The following is a description of a gene set: from publication Chen Y, Wang X (PMID 31504780) Genes predicted to be targets of miRBase v22 microRNA hsa-miR-4731-3p in miRDB v6.0 with MirTarget v4 prediction scores > 80 (high confidence targets). Human Gene Set: MIR4731_3P species: Homo sapiens, and this is the list of marker genes: EPHA5, NUP54, CNOT1, CNOT7 (NCBI Gene Id 29883), SNRPB2, TP53TG3B, GAD2, PCDHA4, ELL2, UBE3A, NECTIN1, SGIP1, DDX3X, HIPK1, RBM27, CYRIA, IRF5, RAB9B, RYBP, SLC16A1, FAM193A, GLRA2, ABHD13, KIF26B, LDHA, LUC7L3, PCDHA5, SCG2, RNF220, ZNF382, ZNF605, UCK2, DOCK3, PCDH9, AUTS2, CCDC71L, CCL23, ASIC2, TP53TG3D, HSPD1, ZNF706, LRP12, RTN4R, JAG2, SCGB2A1, FAM117A, CRKL, NAT1, UBE2B, SLC26A5, PTPN9, PARPBP, RRAS2, TRIO, NAP1L3, CCDC184, ZFPM2, SAMSN1, PCDHA12, RFX3, SRP68, NUDT16, TMEM35A, FBXL5, UBR3, IMMT, ITGB5, DHX38, RB1, TLX1, PITPNB, HACD3, NRP1, BMPR2, PCDHAC1, GTPBP3, TP53INP1, ASAH2B, ZC3H6, SPOCK3, ARNT, ZFR, ERC2, RAP1A, BRWD3, LRRTM3, QRICH1, GPM6A, BIRC6, MEST, MCHR2, SPTLC1 (NCBI Gene Id 3302), DUSP4, NR4A1, PTPRK, PNN, MSR1, LSM4, FAT3, RIMS3, PHC3, MPDZ, ANK3, ROBO2, CNNM4, DACT1, INO80D, DACH1, TBC1D8B, OTUD1, PCDHA2, GOLGA7, KSR2, SIN3A, ABLIM3, ABI1, UGT2A3 (UDP glucuronosyltransferase family 2 member A3), ST8SIA4, MAP7D3, RBX1, FAM91A1, TMA16, USPL1, NDUFAF6, PCDHA11, ARL5A, ALG10B, TP53TG3, PUM1 (pumilio RNA binding family member 1), NUFIP2, MBNL3, MOSPD1, TSC22D2, SFMBT2, HSPH1, SMG7, DIPK2A, CXCR4, UBA2, CLDN8, CFAP61, RIMKLB, NFAT5, ZC3H12C, PCDHA8, CERT1 (NCBI Gene Id 10087), HIVEP1, PCDHA13, USP24, PPP1R15B (NCBI Gene Id 84919), LRRTM4, RNF2, PRKAG2, UBE2H, CSNK1D, NOTCH2, SEC23IP, HECTD2, ZIC4, PCDHA1, SYT1, MACO1, GORASP2, NOVA1, ZMYND8, ARHGAP32 (Rho GTPase activating protein 32), BMPR1A, TEAD3, RNF11 (NCBI Gene Id 26994), MFSD6, PSD3, DCAF5, TMEM106B, NDFIP1 (Nedd4 family interacting protein 1), SGTB, ZCCHC17, TNFRSF19, VSNL1, PCDHA6, RNPS1, PHF3, POLR1B, YWHAH, PTPN4 (protein tyrosine phosphatase non-receptor type 4), NF1, TATDN2, ZNF143, MECP2, PMCH, FGF13, DGKE, PCDHA10, NDRG4, USP1, CCDC85A, CCNL1, SPAG16, MEX3D, SPHKAP, NETO1, ATP2B4, NRN1, HMGB2, TOB1, DIP2B (NCBI Gene Id 57609), AKAP9 (NCBI Gene Id 10582), HOXA5 (NCBI Gene Id 55953), WEE1, ADAMTS10, PI4K2B, PCDHA3, SORL1, CTDSPL2, NWD2, AGFG1, PRTG, FOXO3, KBTBD8 (kelch repeat and BTB domain containing 8), PUM2, IYD, CACNA1C, BAZ1B (bromodomain adjacent to zinc finger domain 1B), PCDHAC2, PABIR3, GABRA6, FAM199X, PCDHA7, RANBP3L